Given this list of marker genes PIK3CB, ANXA1, PIK3CD, HCAR2, FCAR, here is a description of the gene set: Any process that activates or increases the frequency, rate, or extent of neutrophil apoptotic process. species: Homo sapiens Human Gene Set: GOBP_POSITIVE_REGULATION_OF_NEUTROPHIL_APOPTOTIC_PROCESS